Given this list of marker genes H2az2, Ccnb1, H2ac20, H3c7, H3c1, H2ac10, H2bc7, H3c2, Ncapd3, H2ac15, H2ab3, H4c9, H3c6, H4c4, H4c2, H3c15, H2ac8, H3f4, H4c6, H2aj, H2bc15, H2bc24, Smc2, H2ab2, H4c8, H2bc8, Mcph1, H2bc23, H2bc14, H2bc6, H4c3, Ncapg2, H2ab1, H2ac12, H2ac4, H2ac6 (H2A clustered histone 6), H3c10, Plk1, H2ac23, H2bc26, H2bc21, H2bc22, H2bc3, H2ac24, H4c11, H2ac11, H2ac18, H4c18, H3c3, H3f3a (H3.3 histone A), H2ac22, H3c8, Rb1, Smc4, H2ac13, H3c4, H3c11, H2bc4, H4c1, H2ax, H2bc11, H2bc9, Ncaph2, H4c12, H2bc13, Set, Cdk1, H2ac7, H3c14, H3f3b, H2ac19, H2bc1, H4c17, H4c14, H2bc12, H3c13, H4c16, here is a description of the gene set: Mouse Gene Set: REACTOME_CONDENSATION_OF_PROPHASE_CHROMOSOMES Condensation of Prophase Chromosomes species: Mus musculus